Given this list of marker genes SMARCE1, OSBPL2, CACNA1D, DIABLO, AKT1, P2RX2, SDHD, EPAS1 (endothelial PAS domain protein 1), SDHB, TRAF7, LOXHD1, SDHA (NCBI Gene Id 6389), COCH, NF1, FAS, PIK3CA, CYP11B2, ATP1A2, GLA, SLC12A3, JAK2, SCN1A, KCNQ4, DKK1, DLST, PRRT2, NF2, RET, PHEX, MAX, SLC39A14, SLC44A4, AIFM1, FH, MIR96, SMO, VHL, PDGFB, KCNJ5, CAV1, CLCN2, COQ6, CCDC50, ATP2B2, CCND1, GRM1, SDHAF2, SDHC, DSPP, KIF1B, ANKH, PMP22, CYP11B1, LZTR1, MFN2, TMC1, TERT, TMEM127, CLCNKB, NAGA, SLC25A11, PTPN22, SMARCB1, BAP1, ABCC1 (NCBI Gene Id 8133), MDH2, THOC1 (NCBI Gene Id 9984), CACNA1A, DNMT3A, SUFU, here is a description of the gene set: Tinnitus is an auditory perception that can be described as the experience of sound, in the ear or in the head, in the absence of external acoustic stimulation. Tinnitus species: Homo sapiens Human Gene Set: HP_TINNITUS